The following is a description of a gene set: Human Gene Set: REACTOME_SIALIC_ACID_METABOLISM Sialic acid metabolism species: Homo sapiens, and this is the list of marker genes: CTSA, ST3GAL3, ST6GALNAC5, NANS, ST6GALNAC4, ST8SIA6, ST3GAL5, NANP, ST3GAL2, NEU3, NEU4, ST8SIA1, ST6GAL1, ST8SIA4 (ST8 alpha-N-acetyl-neuraminide alpha-2,8-sialyltransferase 4, NCBI Gene Id 7903), ST6GALNAC6, NEU2, ST3GAL1, ST8SIA5, ST6GAL2, ST6GALNAC1, ST6GALNAC2, SLC17A5, NEU1, GNE, GLB1, ST3GAL4, ST3GAL6, SLC35A1, NPL, ST6GALNAC3, CMAS, ST8SIA3, ST8SIA2